The following is a description of a gene set: species: Homo sapiens Human Gene Set: KEGG_MEDICUS_VARIANT_MUTATION_INACTIVATED_ATXN3_TO_AUTOPHAGY_VESICLE_NUCLEATION Mutation-inactivated ATXN3 to autophagy-vesicle nucleation. Pathway ID: N00962. Pathway type: Variant. Pathway class: nt06462 Spinocerebellar ataxia. Pathway Definition from KEGG: ATXN3* // (BECN1+PIK3C3+ATG14+PIK3R4+AMBRA1), and this is the list of marker genes: AMBRA1, ATG14 (NCBI Gene Id 22863), BECN1, PIK3C3, ATXN3, PIK3R4